The following is a description of a gene set: studied in species Homo sapiens Human Gene Set: GOBP_ADHERENS_JUNCTION_ASSEMBLY The aggregation, arrangement and bonding together of a set of components to form an adherens junction. An adherens junction is a cell-cell junction composed of the epithelial cadherin-catenin complex at which the cytoplasmic face of the plasma membrane is attached to actin filaments., and this is the list of marker genes: PIP5K1C, ABI2, ZNF703, FER, JAM3, CTNNB1, PAK2, HIPK1, DSG3, SMAD7 (SMAD family member 7), VCL, RAMP2, ACTB, TBCD, DLG5